Given this list of marker genes Pappa, Dnajc19, Aldh1l2, Nprl3, Mdga2, Pcdh15, Cdc73, Frmd4a, Bach2, Nrg3, Dlc1, Foxp1, Cops7b, Rabgap1, Lhx6, Rab14, Arfgef1, Itgb3bp, Arid4b, Zc3h12c, Rfx7, Hmgn5, Bmp2k, Mark3, Cacna1h, Stag2, Sp5, Rap1b, Snrpd1, Ceacam18, Kmt5a, Neurod6, Map2, Dctn4, Akirin2, Baalc, Ube2g2, Slco1a6, Rp2, Cldn10, Dipk2a, Ythdc2, Cibar1, Inpp5k, Ccdc88a, Zfp281, Acer3, Hivep1, here is a description of the gene set: from publication Chen Y, Wang X (PMID 31504780) Genes predicted to be targets of miRBase v22 microRNA mmu_miR_5107_3p in miRDB v6.0 with MirTarget v4 prediction scores > 80 (high confidence targets). Mouse Gene Set: MIR_5107_3P species: Mus musculus